The following is a description of a gene set: The chemical reactions and pathways resulting in the formation of any organic compound that is weakly basic in character and contains an amino or a substituted amino group. Amines are called primary, secondary, or tertiary according to whether one, two, or three carbon atoms are attached to the nitrogen atom. Mouse Gene Set: GOBP_AMINE_BIOSYNTHETIC_PROCESS studied in species Mus musculus, and this is the list of marker genes: Odc1, Insm1, Slc6a3, Crhr2, Vps35, Sms, Gch1, Epas1, Azin1, Pnmt, Oaz3, Aldh2, Agtr2, Paox, Moxd1, Ldc1 (NCBI Gene Id 332942), Oaz1, Agtr1a, Cyp2d22, Agmat, Oaz2, Srm, Amd2, Hdc, Kl, Gpr37, Dao, Atp7a, Snca, Sat2, Amd1, Dbh, Th, Azin2, Ddc, Hand2, Park7, Tgfb2, Sat1, Prg3, Nr4a2, Moxd2, Gata3 (NCBI Gene Id 14462)